The following is a description of a gene set: species: Homo sapiens The component of an organelle membrane consisting of gene products and protein complexes that are loosely bound to one of its surfaces, but not integrated into the hydrophobic region. Human Gene Set: GOCC_EXTRINSIC_COMPONENT_OF_ORGANELLE_MEMBRANE, and this is the list of marker genes: ATM, BIN1, COQ7 (NCBI Gene Id 51672), BTBD8, ZFYVE1, ATP6V1D, SYN3, SYN1, ATP6V1C1, DOC2A, COQ3, EMC2, COQ2, COQ4, SNX10, ATP6V1B2, COQ5, ATP6V1A, ATP6V1B1, ATP6V1H, COQ6, COQ8A, ATP6V1G1, RPH3A, STXBP5, ATG14, GRIPAP1, ATP6V1G2